The following is a description of a gene set: Mouse Gene Set: GOMF_HISTONE_MODIFYING_ACTIVITY studied in species Mus musculus A catalytic activity that acts on a histone protein. Reversible histone modifications contribute to regulation of gene expression., and this is the list of marker genes: Kmt2a, Dusp21, Hdac2, Chek1, Ctdsp1, Gsk3a, Srpk1, Myo3a, Ppef1, Kdm4c, Kdm4b, Gsk3b, Csnk1e, Mast1, Jmjd6, Setd1a, Aak1, Limk1, Ezh2, Dot1l, Mst1, Pak3, Prmt9, Smok3b, Cdk5, Kdm6a, Ptpn3, Prdm8, Lats1, Stk17b, Csnk1d, Ulk1, Mknk1, Prkaa2, Kdm3a, Ppm1f, Hipk4, Tns2, Phf10, Naa60, Prkx, Stk32a, Dusp18, Mcm3ap, Brpf3, Dusp29, Ulk3, Tbk1, Prmt6, Dusp28, Bmp2k, Pkn1, Sik3, Prkcb, Ksr1 (kinase suppressor of ras 1), Ehmt1, Mapkapk2, Fbll1, Stk11, Csnk1g3, Riok3, Mecom, Nek4, Kat7, Brpf1, Kdm5d, Pikfyve, Ctdnep1, Uhmk1 (NCBI Gene Id 98572, U2AF homology motif (UHM) kinase 1), Dtx3l, Prmt7, Dusp13b, Oga, Usp16, Kdm6b, Rps6kb2, Tssk6, Ppm1d, Ciita, Mknk2, Cdc42bpa, Nap1l2, Vrk1 (NCBI Gene Id 22367), Dclk1, Setd2, Uhrf1, Setd4, Cdc14a, Sirt1, Ndufaf7, Stk35, Kat5, Dapk2, Pdik1l, Map4k1, Ern2, Nek11, Mapkapk3, Nek7, Ptpmt1, Irak1 (interleukin-1 receptor-associated kinase 1), Ptpn7, Oxsr1, Ptpru, Pptc7, Raf1, Mapkapk5, Eya2, Pkm, Setd5, Rskr, Ppm1h, Pkmyt1, Lrrk2, Dusp6, Pask, Ctdp1, Stk32c, Tssk4, Stk16, Ttbk1, Dusp2, Cdc42bpb, Map3k19, Suv39h1, Pgam5, Phf8, Ppm1k, Ripk2, Dyrk1a (dual-specificity tyrosine phosphorylation regulated kinase 1a), Rps6ka5, Mettl22, Nsd1 (NCBI Gene Id 18193), Ep300, Smyd5, Ptprj, Jarid2, Kdm3b, Ptpro, Sik2, Wnk4, Rps6ka4, Dapk3, Hunk, Kdm1a, Cit, Epm2a, Kmt2d, Rsbn1, Cpped1, Cask, N6amt1, Ppp3ca, Ppp3cc, Naa50, Ptprk, Dclk3, Usp49, Ptpn13, Atf2, Ptpn21, Lrrk1, Ash2l, Alpk1, Dusp3, Ptpn20, Ptprc, Cdc25b, Stk38, Tgm2, Setd1b, Rps6ka3, Kat6b (NCBI Gene Id 54169), Tnik, Mysm1, Pcgf5, Jak2, Tssk5, Mast3, Crebbp, Prdm6, Rps6ka6, Cdc14b, Hdac1, Ing3, Suv39h2, Ptp4a1, Ppp4c, Tlk2, Nek5, Nim1k, Ptpn22, Ptpra, Ash1l, Kdm4dl, Suz12, Ubr2 (ubiquitin protein ligase E3 component n-recognin 2), Ppm1g, Ksr2, Gak, Dusp7, Mettl23, Pim3 (proviral integration site 3), Sbk1, Eif2ak4, Taok3, Stk40, Kmt2c, Wnk2, Brca2, Usp51, Huwe1, Ptprh (protein tyrosine phosphatase receptor type H), Rock1, Kdm1b, Ppp6c, Srpk3, Ppm1n, Taf9 (TATA-box binding protein associated factor 9), Eif2ak2, Ptpre, Acp1, Prkaa1, Kmt5b, Stk26, Taok1, Ptprn2, Rnf2, Setmar, Trp53rkb, Kdm5a, Ptprz1, Sgk2, Prpf4b, Ppm1l, Mark3, Setd3, Lmtk2, Hdac3, Sbk3, Trim37, Smok3a, Mink1, Jade1, Msx3, Mtmr3, Eef1akmt1, Ikbkb, Lats2, Ptp4a3, Cilk1, Map4k2, Stk39, Tada2a, Trpm6, Smyd1 (SET and MYND domain containing 1), Sgk3, Ppp2ca, Dusp12, Nsd2, Dcaf1, Gm4922, Ttn, Mos, Chek2, Dusp26, Pak6, Tnni3k, Padi1, Cdk2, Usp3, Stk32b, Rnf20, Padi2, Kdm4d, Jade2, Dclk2, Map4k3, Atm (NCBI Gene Id 77416), Csnk2a2, Smg1, 4921509C19Rik, Pak4, Dusp23, Ptprb, Vcpkmt, Fam20c, Meaf6, Slk, Stk38l, Cdyl, Bub1, Brsk1, Tssk2, Melk, Hdac8, Pdpk1, Wdr5, Ern1, Dusp4, Trpm7, Nek8, Tnk2, Ilkap, Ssh1 (NCBI Gene Id 384311), Ptpn6, Hr, Pik3ca, Mast4, Ublcp1, Hipk2, Rpap2, Phlpp2, Ankk1, Dapk1 (death associated protein kinase 1), Eya4, Riok1, Prkdc, Hat1, Ppef2, Srpk2, Csnk1a1, Pak5, Alpk2, Ptpn11, Hipk1, Ppp3cb, Kdm4a, Alpk3, Ptprt, Cdk1, Dmpk, Akt3, Ripk4, Nat8f7, Smok2a (sperm motility kinase 2A), Pink1, Nat8f3, Ppp5c, Aurka (aurora kinase A), Baz1b, Kdm5b, Ptpn18, Usp22, Nuak1, Naa40, Ripk3, Riox1, Stk-ps2, Ptpn12, Vrk2, Ctdsp2, Csnk2a1, Aurkc, Padi4, Eya3, Ppp1cc (protein phosphatase 1 catalytic subunit gamma), Cdc7, Bap1, Nek6, Brsk2, Ptpn14, Ptp4a2, Stk3, Kat14, Rnf168, Csnk1g1, Ntmt1, Bub1b, Mettl21a, Snrk, Mast2, Dusp1, Ptpn23, Stk31, Ing4, Ssu72, Phlpp1, Kmt5a, Pskh1, Lmtk3, Rps6kc1, Ptprd, Mdp1, Cdc42bpg, Pik3r4, Kat2b, Ppm1a, Rps6ka2, Padi3, Fbl, Kat6a, Ulk4, Pdxp, Gtf2b, Ptpn9, Aatk, Eya1, Atr, Eef1akmt3, Setd7, Myo3b, Tssk1, Csnk1g2, Ppp1ca, Ppm1m, Setdb2, Kat8, Bcr, Prdm9, Brd1, Hipk3, Nek1, Nuak2, Prmt3, Cdc25a, Ptpn4, Phf2, Tlk1, Kalrn, Araf, Ssh3 (NCBI Gene Id 245857), Ctdspl, Nek9, Ptprs, Ttbk2, Stk33, Kdm8, Dnajc6, Usp36, Fbxl19, Prmt8 (NCBI Gene Id 381813), Clock, Dusp8, Kmt2e, Ptprm, Setdb1, Mark1, Pim1, Eif2ak3, Ssh2, Rock2 (Rho-associated coiled-coil containing protein kinase 2), Dusp10, Akt2, Mak, Kdm2a, Sgk1, Ppp1cb, Eef2kmt, Prmt2, Ptprr, Speg, Kdm5c, Braf, Ubash3b, Ncoa1, Mtor, Trio, Setbp1, Jmjd1c, Pim2, Sbk2, Wnk3, Nek2, Pak2, Ncoa3, Pygo2, Smok2b, Pgp, Stk36, Ulk2, Rps6kb1, Ptprv, Mettl8, Ppp2cb, Dusp22, Pten, Kmt2b, Nsd3, Kmt5c (lysine methyltransferase 5C), Mylk4, Ptprg, Stk4, Nrk, Kdm2b, Stk10, Mark4, Pcgf3, Eef1akmt2, Ptpn2, Sik1, Map4k4, Ptprf, Dusp13a, Riok2, Prmt5 (protein arginine N-methyltransferase 5), Acp3, Ppm1e, Taok2, Kdm7a, Ezh1, Taf1, Nek3, Pik3cg, Ptpn5, Nek10 (NIMA (never in mitosis gene a)- related kinase 10), Cdkn3, Prkca, Uty, Taf10, Tssk3, Kat2a, Dusp19, Rps6ka1, Atpsckmt, Stk25, Smyd2, Carm1, Map4k5 (NCBI Gene Id 78253), Phkg1, Riox2, Ptprq, Prdm13, Obscn, Ptpn1, Aurkb (NCBI Gene Id 20877), Msl2, Ripk1, Mtmr4, Map3k7, Mastl, Rps6kl1, Ppm1j, Dusp15, Pak1, Limk2, Gm7168, Smyd3, Ehmt2, Haspin, Mark2, Prmt1, Akt1, Wnk1, Ppm1b, Gtf3c4, Antkmt, Med24, Prdm16, Irak4, Dusp14, Eif2ak1, Stk24, Cdc25c